Given this list of marker genes PIK3CB, BLNK, CBL, HCK, YES1 (NCBI Gene Id 7525), VAV1, PIK3R1, UBA52, PIK3CA, UBC, CRK, SYK, PIK3CD, FYN, PIK3R3, CRKL, PIK3R2, GRB2, RAPGEF1, UBB, LYN, RPS27A, here is a description of the gene set: Reactome Pathway: Regulation of signaling by CBL studied in species Homo sapiens Cbl is an E3 ubiquitin-protein ligase that negatively regulates signaling pathways by targeting proteins for ubiquitination and proteasomal degradation. Cbl negatively regulates PI3K via this mechanism. The binding of Cbl to the p85 subunit of PI3K is mediated at least in part by tyrosine phosphorylation at Y731. Fyn and the related kinases Hck and Lyn are known to be associated with Cbl. Fyn is proven capable of Cbl Y731 phosphorylation.The association of Fyn and Cbl has been described as constitutive. CBL further associates with the p85 subunit of PI3K, this also described as constitutive and mediated by the SH3 domain of p85. Binding of the SH2 domain of p85 to a specific phosphorylation site in Cbl is postulated to explain the the increase in Cbl/p85 association seen in activated cells which negatively regulates PI3K activity. The negative effect of increased Cbl-PI3K interaction is mediated by Y731 of Cbl. Cbl binding increases PI3K ubiquitination and proteasome degradation.<br><br><br>Cbl is constitutively associated with Grb in resting hematopoietic cells. Both the SH2 and SH3 domains of Grb2 are involved. Cbl has 2 distinct C-terminal domains, proximal and distal. The proximal domain binds Grb2 in resting and stimulated cells, and in stimulated cells also binds Shc. The distal domain binds the adaptor protein CRKL. Tyrosine phosphorylation of Cbl in response to IL-3 releases the SH3 domain of Grb2 which then is free to bind other molecules. Cbl is tyrosine phosphorylated in response to many cytokines including IL-3, IL-2 and IL-4. part of: Interleukin-3, Interleukin-5 and GM-CSF signaling